Given this list of marker genes CYP2C8, CYP2E1, CYP3A4, CYP2C9, CYP2D6, CYP1A2, here is a description of the gene set: part of: Biosynthesis of maresins Maresin-like mediators MaR-L1, Mar-L2 and 14,21-dihydroxy docosahexaenoic acids are normally synthesized by leukocytes, platelets and macrophages, via the pathways described here. Impaired production of these specialised proresolving mediators (SPMs) in diabetic skin wounds is associated with impaired macrophage function and delayed or absent wound healing (Brem & Tomic-Canic 2007, Boniakowski et al 2017). Macrophages play critical roles in wound healing by mechanisms as yet unknown. They are active in both the initiation (M1 macrophage phenotype) and the resolution (M2 macrophage phenotype) of inflammatory processes. In a pathological state, the switch from the M1 phenotype macrophage to the M2 phenotype macrophage may be delayed or fail to occur, which can result in chronic low-grade inflammation. This macrophage phenotype skewing toward an inflammatory phenotype has been implicated in the pathogenesis of type 2 diabetes (T2D) and the non-healing of diabetic wounds.<br><br>Administration of maresin-like SPMs to diabetic mice with induced wounds have been shown to act as autocrine/paracrine factors in restoring reparative functions of macrophages. species: Homo sapiens Reactome Pathway: Biosynthesis of maresin-like SPMs